Given this list of marker genes MYO19, TRAK1, TRAK2, RAP1GDS1, RHOT1, here is a description of the gene set: Reactome Pathway: RHOT1 GTPase cycle This pathway catalogues guanine nucleotide exchange factors (GEFs) and effectors of RHOT1 (also known as MIRO-1). RHOT1 possesses a high intrinsic GTP-ase activity and does not require a GTPase activator protein (GAP). No GDP dissociation inhibitors (GDIs) have been reported to interact with RHOT1. RHOT1 is a mitochondrial RHO GTPase. Like related RHOT2 (MIRO-2), RHOT1 localizes to the outer mitochondrial membrane. RHOT1 is implicated in mitochondrial movement inside the cells, including the axonal transport of mitochondria in neurons, as well as mitochondrial fission and fusion. RHOT1/RHOT2-mediated mitochondrial turnover is affected in neurodegenerative diseases. RHOT1 can localize to peroxisomes and regulate peroxisome motility and fission. RHOT1 is also involved in the regulation of ER-mitochondria membrane contact sites.<br>Upregulation of RHOT1 has a neuroprotective effect in ischemic stroke. studied in species Homo sapiens part of: Miro GTPase Cycle